Given this list of marker genes GSN, SNX7, CNKSR3, HPDL, ST8SIA6, TGFB3, BMPR1B, HAGHL, SPMIP5 (sperm microtubule inner protein 5), NPRL3, DDHD2, GPR137B, CLIP1, LACTB, RAB37, DENND3, GRK4, CTPS2, SH2B2, H2BC13, BRD9, DENND1C, GPR180, SUOX, MAP7D1, SLC2A8, GCSAM, IPMK, AGO4, CEP44, CARD19, ANXA2, PTTG1IP, MEF2B, SPSB4, PRKACA, ORAI2, ARHGEF4, PLBD1, VTN, PFKFB2, LUZP2, CEP164, BCCIP, STARD10, MXD4, CAMKMT, SMIM14 (NCBI Gene Id 201895), PGP, DHX57 (DExH-box helicase 57), HOPX, MS4A2, LIPA, MEX3B, UBE2E2 (NCBI Gene Id 7325), RAB3GAP2 (RAB3 GTPase activating non-catalytic protein subunit 2), MEF2D, GPAT3, NPHP3, PGAP1, RCAN3, JARID2, SPNS3, SLC25A24, ATL1, MYCL, HNRNPR, GNAT1, EMP3, COTL1, CYP39A1, SERHL2, NUDCD2, HSD17B11, LPP-AS2, TNFAIP8, PLEC, TAF1B, CTNS, KCNJ1, SFXN4 (NCBI Gene Id 94084), ADAMDEC1, RCN2, DDX17, KHK, SIRT4, TBC1D25, FAM135A, EIF5A2, CASP6, JMJD1C, ANAPC11, TRIM13, SHLD2, EIF2AK3, PGM2, B3GALNT1, FAM221B, TUBA1A, TMEM80, LIPC, CDKL2, MAPK3, CPEB4, TMEM191C, NXF2, RAD17, AGA, RAPGEF3, CEP250, HEPACAM2, USO1 (USO1 vesicle transport factor), ZSWIM3, ERCC5, TESK1, IL31, ARRB2, DHRS1, IKZF1, RPL30, NRARP, L1CAM, ZNF317, RDH12, ZMYND8, HSDL2, CRYL1, GOLM2, SESN3, HES1, PCYOX1, LDLR, KLK8, ATRNL1, CAT, EDARADD, SMPD2, MEGF9, CAMK2G, SSPN, GPR155, PCK1, KIF12, DMD, SBK1, TMEM30A, AGPAT4, ACAD10, CRISP3, ZDHHC23, TSPAN13, CHRNB1, GUCD1, LAMTOR4, ZDHHC20, GM2A, RAP1GDS1, C3orf62, TTPAL, RBMX, EMC2, PRR12, EEF2K, RTN1, TET1, PAN2 (poly(A) specific ribonuclease subunit PAN2), CIB2, PGM3, SOX9, XKRX, TIPIN, PSMB11, KLF6, GMEB1, SMC5, SCCPDH, SLC37A3, CAMK2N1, ACADM, SAMD1, EIF2AK4, RIC8A, DAG1, CILK1, TPRG1L, GRAMD1C, REEP2, TAX1BP3, FCER2, CCNDBP1, STX2, THY1, GMPR2, SLC12A5, MYO6, ABCA5, IL13RA2, GGA2, IFNAR1, POT1, here is a description of the gene set: from publication Kaji T, Ishige A, Hikida M, Taka J, Hijikata A, Kubo M, Nagashima T, Takahashi Y, Kurosaki T, Okada M, Ohara O, Rajewsky K, Takemori T (PMID 23027924) Human Gene Set: GSE11961_MEMORY_BCELL_DAY7_VS_MEMORY_BCELL_DAY40_DN To obtain insight into the genetic basis of the increase of functional activity of memory B cells over time, we compared the gene expression profiles of day 7 and day 40 NP-specific/IgG1 memory B cells, GC B cells and plasma cells in immunized WT mice and naïve B cells, before and after activation in vitro. Genes down-regulated in day 7 memory B cells versus day 40 memory B cells. studied in species Homo sapiens